Given this list of marker genes Crlf2, Tnfrsf9, B2m, Gzma, Canx, Bcl2a1b, Erh, H2-K1, Crem, Metrnl, Tmed5, Oas1a, Lfng, Vps29, Serpina3g, Prf1, Gzmb, Fyb1, Sh2d2a, Pmepa1, Cd53, Tmsb10, Gatad2a, Abcb1a, Runx3, Bst2, Dgat1, Ifngr1, Camk2n1, Lilrb4b, B4galt5, Zfp110, Hspa5, H2-Q7, Sipa1l1, Gstp1, here is a description of the gene set: Mouse Gene Set: CUI_NK_CELL_IL36A_RESPONSE_UP Genes positively differentially expressed in cell type: NK cell upon treatment with cytokine: IL-36α in mouse lymph nodes in vivo. from publication Cui A, Huang T, Li S, Ma A, Pérez JL, Sander C, Keskin DB, Wu CJ, Fraenkel E, Hacohen N (PMID 38057668) Cytokines mediate cell-cell communication in the immune system and represent important therapeutic targets. A myriad of studies have highlighted their central role in immune function, yet we lack a global view of the cellular responses of each immune cell type to each cytokine. To address this gap, the authors created the Immune Dictionary, a compendium of single-cell transcriptomic profiles of more than 17 immune cell types in response to each of 86 cytokines (>1,400 cytokine-cell type combinations) in mouse lymph nodes in vivo. A cytokine-centric view of the dictionary revealed that most cytokines induce highly cell-type-specific responses. For example, the inflammatory cytokine interleukin-1β induces distinct gene programmes in almost every cell type. A cell-type-centric view of the dictionary identified more than 66 cytokine-driven cellular polarization states across immune cell types, including previously uncharacterized states such as an interleukin-18-induced polyfunctional natural killer cell state. species: Mus musculus